Given this list of marker genes PHB2, LEP, NPR3, RFK, IL1B, GCH1, DRD5, MT3, OXA1L (NCBI Gene Id 5018), EDN1, NT5DC2, SIRT3, NOSIP, SNCA, PRKN, COX17, GLA, INS (insulin), EDN2, ECSIT, GZMA, PRDX5, CDH3, SIRT4, SZT2, ESR1, FGF23, SPHK2, here is a description of the gene set: Any process that modulates the frequency, rate or extent of oxidoreductase activity, the catalysis of an oxidation-reduction (redox) reaction, a reversible chemical reaction in which the oxidation state of an atom or atoms within a molecule is altered. One substrate acts as a hydrogen or electron donor and becomes oxidized, while the other acts as hydrogen or electron acceptor and becomes reduced. studied in species Homo sapiens Human Gene Set: GOBP_REGULATION_OF_OXIDOREDUCTASE_ACTIVITY